The following is a description of a gene set: Human Gene Set: MIR1178_3P from publication Chen Y, Wang X (PMID 31504780) Genes predicted to be targets of miRBase v22 microRNA hsa-miR-1178-3p in miRDB v6.0 with MirTarget v4 prediction scores > 80 (high confidence targets). studied in species Homo sapiens, and this is the list of marker genes: SUZ12, PTPN5, GABRB2, ATAD2B, HNRNPR (heterogeneous nuclear ribonucleoprotein R), ZNF577, GPAM, ATP1B1, EGR3, TMPRSS11E, CDH23, AADAC, WDR48, ADAM9, CXCL6, NUS1, COL19A1, MMGT1, STMN2, DNAH6, RIMBP2, PCDHB10, CEP126, PDPK1 (3-phosphoinositide dependent protein kinase 1), RIMKLA, ZZZ3, GLS, FAM98A, ZNF510, LYPD1, ZMAT4, TUB, SNCA, ABCA12, SUPT7L, FAM199X, KLRG1, LZTS3, ZXDC, SLC39A6, MYH10, CENPI, AMMECR1, ATG5, SPTLC1, ZNF701 (zinc finger protein 701), GABRA5, SEZ6L2, EWSR1, ARHGAP31, NUTM2G, GNAS, EIF1B, ASB7, SLC45A3, ELK4, ALDH1B1, RORA, NAA30, DCUN1D3, PEX11A, LEMD3, ATXN1, MYO5B, TMEM184B, AFF4, MAGI2, DLG1, CDH13, BCL2, HERPUD1, FNDC3B, PPP3CB, SRPRA, ZNF888, CDK8, SLC5A12, SNU13, CRY2, ZNF385A, MAT2A, TSPYL4, CNOT6L, NPTN, NUDT21, MAP3K2, GPM6A, IPO5, HHIP, SPAG9, MSL3